The following is a description of a gene set: Genes up-regulated in epithelial cells (24h): untreated versus interferon alpha and IFNG. studied in species Homo sapiens Human Gene Set: GSE5542_UNTREATED_VS_IFNA_AND_IFNG_TREATED_EPITHELIAL_CELLS_24H_UP from publication Sanda C, Weitzel P, Tsukahara T, Schaley J, Edenberg HJ, Stephens MA, McClintick JN, Blatt LM, Li L, Brodsky L, Taylor MW (PMID 16800785) Type I and type II interferons (IFNs) bind to different cell surface receptors but activate overlapping signal transduction pathways. We examined the effects of a type I IFN (IFN-acon1) and a type II iFN (IFN-g1b) on gene experession in A549 cells and demonstrate that there is a common set of genes modulated by both IFNs as well as a set of gene specifically regulated by each, reflecting the activation of different signaling pathways. In particualr, IFN-g induced many more genes of the signaling pathways, apoptosis, and cytokine interactions than did IFN-a. Even with genes induced by both IFNs there were distinctive quantitativive differences in expression. IFN-g1b plays a major role in the induction and regulation of the complement pathway. Previous work has shown a synergistic antivral and antiproliferative effect of type I and type II IFNs in cell culture and in the treament of tumors in mice. We demonstrate that a majority of genes showed and additive effect of IFN-acon1 and IFN-g1b, but a subset of gene is synergistically induced; these incluce ISG10, MX2, OAS2, and other genes known to be involved in the antiviral response, TRAIL (TNFSF10) and caspases involved in apoptosis and chemokine genes RANTES, CXCL10, and CXCL11. Greater than additive transcription of some of these genes in the presence of both IFNs was confirmed by real-time kinetic RT-PCR. Elevated induction of many of these genes may be sufficient to explain the synergistic antiviral and antitumor effects of this combination of IFNS in vivo., and this is the list of marker genes: CPA3, MRPL48, RBPJ, RALBP1, SUCO, TXNIP, DIAPH2, EPRS1, ADAT2, DANCR, RPL37A, KAT7 (lysine acetyltransferase 7), GSTM3, BFAR, TRAK1, CCDC47, LIN28A, PECR, GTF2A2, ADGRE5, TOMM70, ACAA1, PBDC1, ELOF1, AP2B1, SPATA1, RIOK1, PFDN4, GLOD4, SNX9, COPS5, AFG3L2, ERLEC1, XPOT, GXYLT1, CCNL1, PFKFB4, SCAF1, TRPM7, MAPK13, ARHGAP19, TM9SF4, POLD2, IMMT, MALAT1, PSMB7, CEP128, HNRNPA1, ADPRH, PHB2, AFF2 (NCBI Gene Id 2334), COG7, STX6, UQCRQ, TICRR, SLC48A1, USF2, CDC123, NDUFAF7, MRPS26, PLXND1, PSMD13, KIF20A, ERI2, ZMIZ1, DNLZ, TSC22D3, GALE, MLKL, TRIB1, FEM1C, NAT8L, CEP164, CHEK1, MACC1, MRPL41 (mitochondrial ribosomal protein L41), FRA10AC1, C2CD5, ZEB2, APPL2, SCO1, RGS1, EDIL3, CAMKK1, SNRPB2, SHC1, SLC6A6, VOPP1, PPM1B, TRMT10C, RTCB, FBXL6, RIC8A, DHRS4, WDR44, B9D2, UIMC1, TMEM241, NSMCE4A, NSA2, ATP1B3, AQP9, SOCS3, PTPN22, ATF6B, MYO5A, RARB, ARIH2, CEP44, ZFAND2B, MARCHF3, GPAA1, B3GNT5, DBF4, CARNS1, CD14, SART1, TEX261, CCNYL1, TAP2, RABGAP1L, TTC39B, NT5DC1, TMEM40 (NCBI Gene Id 55287), NDUFS6 (NADH:ubiquinone oxidoreductase subunit S6), NDEL1, CDK2AP1, SMPD5, KLHL30, B4GALT5, PTPRA, BCR, OXSM, RTEL1, KLF9, DHRS1, TEFM, PABIR2, EXOSC1, RECQL, UBE2S, GPC1, NME7, TBXAS1, SEC63, DIAPH3, RMC1, MREG, ECPAS, FKBPL, VAMP2, MPEG1, COPZ1, TMEM273, SLC36A4, EIF3M, ZCCHC4, PBX1, BSCL2, PNN, GLE1, CDC42BPG, IFT57, RPL18, ESD, PDCD6, ATP10A, YJU2, HLCS, MCM9, SMARCA5, NMT1, SLC8B1, TRAFD1, TSPOAP1, PLRG1, TOR1A, MPHOSPH6, MTFR1, MRPL27, CST7, TNFAIP6, IPO11, PRSS50, SLFN13, HAGHL, CENPK, WDR81, TMEM86B, SWI5, HLA-DRB1, VEGFA (NCBI Gene Id 7422), WWTR1, PHLDA1, ZWILCH, CCT6A, IPO5, RTP4, RPS11